The following is a description of a gene set: studied in species Mus musculus from publication Chen Y, Wang X (PMID 31504780) Genes predicted to be targets of miRBase v22 microRNA mmu_miR_3110_5p in miRDB v6.0 with MirTarget v4 prediction scores > 80 (high confidence targets). Mouse Gene Set: MIR_3110_5P, and this is the list of marker genes: Lmln, Itga9, Scai, Setd7, Mgat4a, Gabra2, Cstf3, Dtd1, Tnik, Lpp, Utp14b, Rgs8, Slc30a4, St8sia2, Zfc3h1, Rab37, Ston2, Prdm15, Zmym3, Ddx3x, Adamtsl1, Gnal, Zfp354b, Dsc3, Slc25a36, Foxp4, Lmbr1, M6pr, Cops2, Slc16a5, Enox1, Lox, Phc1, Eif2b1, Vps37a, Ebf2, Arb2a, Cdc42se1, Palld, Slc35e1, Adra2a, Tcf15, Rbm39, Tia1, Zfp827 (zinc finger protein 827), Zfp92 (NCBI Gene Id 22754), Tmco4 (NCBI Gene Id 77056), Vash1, Wnt10a (NCBI Gene Id 22409), 1700017B05Rik, Mapre1, Mast3, Rad51c, Nr0b1, Ldlr, Usp34, Lats2, Kcnb1, Upf2, Vcpip1, Ttpal, Odc1, Cep97, Nav1, Desi2, Trem6l, Snap29, Snu13, Fam13a, Zfand5, Fes, Mtx3, Zfp711, Rnase6, Camk1d, Gtf2e1, Tnrc6b, Thsd7b, Gata3, Naip6, Orai2, Alg11 (NCBI Gene Id 207958), Nr4a2, Pole (NCBI Gene Id 18973), Hip1, Mettl21e, Phactr2, Tpbgl, Pum2, Gpsm2, Sele, 5730455P16Rik, Lhfpl2